Given this list of marker genes VPS16, ZMYND11, HSD17B10, EP300, CHD5, TBP, NSD2, WDR45, NFIB, CAMK2B, KDM3B, TMEM147, ECM1, PRODH, SUCLG1, NAA10 (NCBI Gene Id 8260), UBE3C, TRIP12, TSC2, SARS1, NSDHL, CHD2, PRNP, PYCR2, MED25, BCORL1, TRIO, ATP9A, PRKAR1B, GAMT (guanidinoacetate N-methyltransferase), AP1G1, RAP1GDS1, PPP2R5D, ESS2, NDP, APC2, MBD5, ZFX, CACNA1A, GRN, BRF1, GRIA3, ATP13A2, EBP (NCBI Gene Id 139151), MAN1B1, MAOA, KCNT1, LINS1, BPTF, DGCR8, SLC6A17, MAB21L1, VCP, TTC19, WDR62, KDM5C, SATB2, ARID1B, ANK3, DPYD, PUS3, CDC42BPB, HTT, RNU4-2, STEEP1, UQCC2, RLIM, PGM2L1, MECP2, EFHC1, MAPK1, RBBP8, SLC4A10, FERRY3 (FERRY endosomal RAB5 effector complex subunit 3), ODC1, FRRS1L, PTCHD1, PUS7, BCAP31, SETD2, UBE2A, HDAC4, IQSEC1, EEF1A2, SOX5, DNM1, COQ5, PSEN1, CNTNAP2, SMARCB1, SMARCC2, LINGO1, SOX11, EHMT1, TAF4, MED12L, KMT2A, CREBBP, GRIK2, WARS2, KDM4B, NRCAM (NCBI Gene Id 4897), FMO3, ALG14, TFE3, HEPHL1, DYNC1I2, SCN1A, TREM2, RUSC2, SCAF4, SH2B1, SLC6A8, CHMP2B, SETBP1, ENTPD1, DGCR2, BCKDK, PDE2A, SLC2A1, SYN1, ARID2, OCRL, ALDH5A1, NAGLU, EIF2S3, KCNQ3, IFNG, APOE, RFX7, SHMT2, PIDD1, EBF3, ACBD6, LEPR, AGO1, PAK3, SPR, ATP7B, GABRD, SHANK3, PHIP, PLA2G6, SLC25A13, SRCAP, DEAF1, CASP2, NDST1, NSD1, ADNP (activity dependent neuroprotector homeobox), POGZ, KNL1, SLITRK1, DHCR7, FBXL3 (NCBI Gene Id 26224), WAC, COG3, DPAGT1, DPF2, TCF20, SMARCA4, ADSL, TIMM50, USP7, KIF11, SLC52A2, JRK, NBEA, CEP290 (NCBI Gene Id 9707, centrosomal protein 290), ELP2, CYP27A1, ZBTB20 (NCBI Gene Id 26137), HTRA1 (HtrA serine peptidase 1), USP9X, KDM5B, PSMD12, SLITRK2, TMEM231, CUX2, CHKA, KMT2E, LMAN2L, TTC5, IQSEC2, UROC1, SLC1A3, METTL5, GABRA1, HDC, CHD8, CILK1, NKAP (NFKB activating protein), SPTBN1, HERC2, NSUN6, SLC32A1, SUPT16H, POU4F1, NEXMIF, ATP1A2, SMARCA2, TSC1, SOX4, ATXN10, TMEM106B, FRMPD4, DPYSL5 (NCBI Gene Id 56896), FTSJ1, TYROBP, GDAP2, KMT5B, JARID2, FOXP1 (forkhead box P1), ZMIZ1, NAXD, MAPK10, PAH, ARPC4, TBX1, TMEM67, NONO, TTI2, FGF14, ALDH4A1, NIPBL, SPAST, PRRT2, MGAT2, HNRNPH2, WBP4, GABRB3, DDX3X, HIVEP2, SLC2A3, MED12, CTCF, IMPA1, AHDC1, TMEM222, SASS6, PIGH, TMEM240, RORB (RAR related orphan receptor B), UBE4A, SMARCE1, DNMT3A, CTNNB1, CLCN4, AGO2, PACS1, ADAT3, ASPM, CUL4B, FMR1, CAMTA1, GNB1, PIGY, UBTF, NFASC (NCBI Gene Id 23114), PIGL, MAPT, ATP1A3, CEP152, PCDH19, ARID1A, DYRK1A, BCOR, GLDC, PSMB1, MANBA, GRIN2A, MED13L, HECTD4, INPP5E, VPS13A, CACNB4, PSEN2, SETD1A, SIN3A, SQSTM1, FIG4, SMARCD1, NAGS, GNS, DGCR6, TRAPPC10, AP1S2, AFF2, PANK2, DCDC2, MYT1L, STT3A, CEP85L, CLCN2, ABCA2, CAPRIN1, FBXW11, UBAP2L, TCF4, TDO2, SPEN, here is a description of the gene set: Human Gene Set: HP_AGGRESSIVE_BEHAVIOR Aggressive behavior studied in species Homo sapiens Behavior or an act aimed at harming a person, animal, or physical property (e.g., acts of physical violence; shouting, swearing, and using harsh language; slashing someone's tires).